Given this list of marker genes MAP2K1, AGER, TNF (NCBI Gene Id 7124), NRAS, NOS2, MAP2K2, HRAS, MAPK3, IL6, KRAS, MAPK1, BRAF, RELA, APP, RAF1, NFKB1, ARAF, here is a description of the gene set: studied in species Homo sapiens Mutation-caused aberrant Abeta to AGE-RAGE signaling pathway. Pathway ID: N00996. Pathway type: Variant. Pathway class: nt06460 Alzheimer disease. Human Gene Set: KEGG_MEDICUS_VARIANT_MUTATION_CAUSED_ABERRANT_ABETA_TO_AGE_RAGE_SIGNALING_PATHWAY Pathway Definition from KEGG: APP* -> Abeta -> AGER -> RAS -> RAF -> MEK -> ERK -> NFKB => (TNF,IL6,NOS2)